The following is a description of a gene set: Reactome Pathway: Regulation of actin dynamics for phagocytic cup formation part of: Fcgamma receptor (FCGR) dependent phagocytosis species: Homo sapiens The actin cytoskeleton is fundamental for phagocytosis and members of the Rho family GTPases RAC and CDC42 are involved in actin cytoskeletal regulation leading to pseudopod extension. Active RAC and CDC42 exert their action through the members of WASP family proteins (WASP/N-WASP/WAVE) and ARP2/3 complex. Actin filaments move from the bottom toward the top of the phagocytic cup during pseudopod extension., and this is the list of marker genes: WIPF1, NCKAP1, MAPK1, IGKV1D-39, IGLV1-36, IGKV1-16, NCKAP1L, MYO1C, CD3G, IGHV3-11, IGKV1-12, IGHV4-34, IGLV3-25, ACTB (NCBI Gene Id 60), IGHV2-70, IGHV1-2, IGHV1-69, IGLV1-51, IGKV3-20 (NCBI Gene Id 647478), MAPK3, ARPC5, VAV1, ARPC2, VAV3, MYH2, IGKV2-28, WASF3, BRK1, WAS, IGHV, IGLV3-27, IGHV1-46 (immunoglobulin heavy variable 1-46), IGKV2D-30, CD247, IGLV5-45, IGKV1-39, IGKV4-1, IGKV2-30, IGHV4-39, ABL1, IGLC1, IGLV3-12, ARPC1A, NCK1, RAC1 (NCBI Gene Id 5879), CYFIP1, IGHV3-48, IGLV2-23, IGLV11-55, IGLC2, ELMO2, IGHV3-30, BAIAP2, WASF2, ARPC4, IGLV8-61, IGLV3-16, IGHV3-53, IGHG2, PTK2, IGLV4-69, VAV2, IGLV2-33, IGHV2-5 (NCBI Gene Id 28457), IGKV3-11, IGHG3, IGKV2-29, IGKV1-33, NF2, IGHG4, IGLV, BTK, IGLV1-44, IGLV3-21, IGKV3-15, IGHV4-59, IGLV5-37, WASL, IGKV1D-16, IGLV3-1, IGKV5-2, ACTR3, IGKV1-17, IGKV1-5, IGHV7-81, FCGR1A, IGLC3, IGLC7, DOCK1, HSP90AA1 (heat shock protein 90 alpha family class A member 1), IGLV2-14, IGHG1, ELMO1, WASF1, IGKV2D-28, CDC42, ARPC3 (NCBI Gene Id 10094), IGLV1-47, PAK1, IGHV3-33, FCGR3A, ABI1, LIMK1, IGLV2-18, GRB2, WIPF2, IGLV10-54, IGLV7-43, IGLV4-60, IGKV3D-20, CRK, IGHV3-13, MYH9, IGHV3-7, HSP90AB1, IGLV1-40 (NCBI Gene Id 28825), IGKV1D-33, CFL1, IGLV4-3, SYK, MYO10, IGLC6, IGKC, ARPC1B, IGHV3-23, CYFIP2, ACTR2, ACTG1, IGKV1D-12, IGLV3-22, IGLV2-8, FCGR2A, ABI2, IGLV7-46, IGKV2D-40, WIPF3, NCKIPSD, IGLV6-57, IGLV2-11, MYO5A, IGHV3-9, IGLV3-19, MYO9B